The following is a description of a gene set: species: Homo sapiens Genes up-regulated in B lymphocytes: anti IgM versus anti IgM and CpG oligodeoxynucleotide 1826. We have previously shown that rheumatoid factors (RF) produced by Fas-deficient autoimmune-prone mice typically bind autologous IgG2a with remarkably low affinity. Nevertheless, B cells representative of this RF population proliferate vigorously in response IgG2a/chromatin immune complexes through a mechanism dependent on the sequential engagement of the BCR and Toll-like receptor 9 (TLR9). To more precisely address the role of both receptors in this response, we analyzed the signaling pathways activated in AM14 B cells stimulated with these complexes. We found that the BCR not only serves to direct the chromatin complex to an internal compartment where it can engage TLR9 but also transmits a suboptimal signal that in combination with the signals emanating from TLR9 leads to NF-kappa-B activation and proliferation. Importantly, engagement of both receptors leads to the upregulation of a group of gene products, not induced by the BCR or TLR9 alone, that include IL-2. These data indicate that autoreactive B cells, stimulated by a combination of BCR and TLR9 ligands, acquire functional properties that may contribute to the activation of additional cells involved in the autoimmune disease process. from publication Busconi L, Bauer JW, Tumang JR, Laws A, Perkins-Mesires K, Tabor AS, Lau C, Corley RB, Rothstein TL, Lund FE, Behrens TW, Marshak-Rothstein A (PMID 18025183) Human Gene Set: GSE6674_ANTI_IGM_VS_ANTI_IGM_AND_CPG_STIM_BCELL_UP, and this is the list of marker genes: SUSD1, NDRG3, SPICE1, COMMD8, ERLEC1, HSDL2, CYLD, TAP1, BCL6, CD84, MTHFS, RDH12, SORD, HLA-DOA, FRMD8, STXBP3, UROD, TBX6, AIPL1, PARP8, TSTD1, ZPBP2, STK38, IQCG, CCDC28A, MAP1LC3B, EPHX1, PMM2, TUBB2B, SLC17A7, ARHGEF18, PINK1, PHF21A, SKA1, GLT8D1, ARHGAP18, SEPTIN6, SAMHD1, FAS, LYPD6B, IFT122, TG, RTN3, MDM1, ASAP1, LSP1, HACL1, TOX4 (NCBI Gene Id 9878), PGM2L1 (phosphoglucomutase 2 like 1), IFT140, RANBP10, PAQR7 (NCBI Gene Id 255358), AP5M1, CAT, LRIF1, TSC1, POLR3C, TUBB2A, PIP4K2A, YPEL2, DZIP1, OTUD1, EMC9, PIERCE2, MKRN1, TMEM218, HEXB, CEP120, MBD1, POLR3GL, CENPP, UMAD1, PRPF18, MAP2K6, RSPH3, SESN1, ABCA7, AP1S3, STARD3, ST8SIA1, TTC9C (NCBI Gene Id 283237), PARP9, IVD, GRAP, KLHL6, RIPOR2, LCMT1, YPEL3, SUPT4H1, PPP2R5A, CYP2S1, ZFAND6, DDX6, CD9, ZNF436, SDF2, GDI2, LZTFL1, BCKDHA, RAB43, AK3, ESYT2, CEP128, RNF144A, IL16, CTPS2, CD247, GSE1, ABCD1, KIAA0040, TENT5C, KLC4, PSAP, AKR1A1, LEPROT, FAM221A, ARL4D, TTC39B, N4BP2L1, DGKA, IK, FAM32A, SPOP, TRAF3IP3, SPO11, ADGRE5, ANKRD13A, GLCCI1, NGLY1, TLK1 (tousled like kinase 1), CENPL, SLC25A20, LPAR6, TCTA, SPATA6, CENPT, GSAP, MRPL9, PTTG1IP, EVL, TCF7, TRIM25, GDPD3, PBXIP1, DENND1C, GNAI3, ARHGAP45, CARD6, PECAM1, CPT1A, NEU3, ZNF250, MAP3K3, MTMR14 (NCBI Gene Id 64419), BRDT, FNDC7, SPATA13, TCP11L2, ADD3, SYT11, TMEM71, MTURN, CYTH3, C19orf12, SNRNP25, LRRC28, IKZF3, SLC12A8, CFAP210, RASA3, SLC25A45, CABCOCO1, HROB, HIP1R, ENTREP3, APOBEC3B (apolipoprotein B mRNA editing enzyme catalytic subunit 3B), RB1CC1, H2AC25, MSRB1, ACTN1 (NCBI Gene Id 87), GLRX, LAPTM5, THTPA, RFX5 (NCBI Gene Id 5993), S1PR4, GLIPR1, SLA, ZRANB3, AIDA, RIN3, TUBA1A, TXNDC16, GRAMD2B, TMEM229B, KIZ, TAPBPL, INPP1, OSBPL9, DCAF11